The following is a description of a gene set: Mouse Gene Set: CUI_B_CELL_CD40L_RESPONSE_UP Genes positively differentially expressed in cell type: B cell upon treatment with cytokine: CD40L in mouse lymph nodes in vivo. from publication Cui A, Huang T, Li S, Ma A, Pérez JL, Sander C, Keskin DB, Wu CJ, Fraenkel E, Hacohen N (PMID 38057668) Cytokines mediate cell-cell communication in the immune system and represent important therapeutic targets. A myriad of studies have highlighted their central role in immune function, yet we lack a global view of the cellular responses of each immune cell type to each cytokine. To address this gap, the authors created the Immune Dictionary, a compendium of single-cell transcriptomic profiles of more than 17 immune cell types in response to each of 86 cytokines (>1,400 cytokine-cell type combinations) in mouse lymph nodes in vivo. A cytokine-centric view of the dictionary revealed that most cytokines induce highly cell-type-specific responses. For example, the inflammatory cytokine interleukin-1β induces distinct gene programmes in almost every cell type. A cell-type-centric view of the dictionary identified more than 66 cytokine-driven cellular polarization states across immune cell types, including previously uncharacterized states such as an interleukin-18-induced polyfunctional natural killer cell state. species: Mus musculus, and this is the list of marker genes: Exosc1, Sumo1, Nol6, Adprh, Rrp1b, Atp5mk, Hdgf, Ran, Rhno1, Mydgf, Adsl (adenylosuccinate lyase), Manf, Fbl, Ppp1r14b, Kdm4c, Atp5mc1, Set, Trappc4, Trmt61a, Gnl3, Tmem203, Ssb, Cct3, Ranbp1, Alyref, Znhit6, Psme2, Nop58, Bcas2, Phb1, Dnajc10, Smyd5, Cyc1, Mybbp1a, Tubb5, Tia1, Glyr1, Mthfd1, Ebna1bp2, Mob1b, Ncl, Bcl2a1b, Sms, Prep, Gatad2a, Shmt2, Ubqln1, St13, Atp5pd, Timm44, Alkbh1, Lamtor4, Phf23, C1qbp, Myl12a, Eri3, Drap1 (DR1 associated protein 1), Caprin1, Gspt1, Rsl1d1, Fcer2a, Nars1, Sgta, Park7, Cdk4, Polb, Slamf7, Ndufs8, Pfdn4, Slc39a1, Rnps1, Cdca7, Sde2, Sdf2l1, Gars1, Dhx16, Diablo, Nudc, Dctpp1, Il4i1, Gpatch4, Mphosph10, Khdrbs1, Umps, Odc1, Tkt, Psmd11, Eif3b, Mrpl54, Edaradd, Hspd1, Ube2r2, Exoc3, Fam169b, Tmcc1, Cmss1, Aprt, Hspa9, Pgs1, Nme1, Ube2v2, Ddx18, Sar1b, Txnl1, Cdv3, Mrpl12, Hmbs, Hsp90ab1, Cyba, Flad1, Mdn1, Eif2s1, Nop14, Tagln2, Lsm7, Bzw2, Eif2s2, Prmt3, Mrps24, E2f4, Psmb2 (proteasome (prosome, macropain) subunit, beta type 2), Dkc1, Zc3h15, Mif, Zfp593, Golga4, Eif4a3, Ormdl3 (NCBI Gene Id 66612), Cad, Anp32b, Timm13 (translocase of inner mitochondrial membrane 13), Eftud2, Rbm4b, Pa2g4, Dnajb11, Ppia, Pdia6, Calr, Mettl1, Nop56, Pfn1, Eif1ad, Ahctf1, Lyar, Grap (GRB2-related adaptor protein), Erg28, Sarnp, Utp11, Psma5, Uqcc2, Hspa5, Surf2, Rbmxl1, Il21r, Pam16, Psmc3, Ppa1, Psmb5, Chchd1, Nab1, Eif5a, Cct8, Lap3, Nsun2, Rrp9, Erh, Osgep, Acat1 (acetyl-Coenzyme A acetyltransferase 1), Hsp90b1, Dimt1, G3bp1, Josd2, Apex1, Taf10, Mrpl24, Eef1e1 (eukaryotic translation elongation factor 1 epsilon 1), Ubap2, Polr3h, Ddt (D-dopachrome tautomerase), Marcksl1, Atp5f1e, Fbxo7, Mars1, Psmc4, Ptma, Mrpl23, Utp18, Eif4a1, Cd44, Pkm, Srm, Mrto4, Snrpa, Psme3, Prmt1, Hnrnpd, Fbxl6, Anapc2, Wdr11, Dus2, Nr2c2ap, Mrpl21